Given this list of marker genes GSTT2, DPAGT1, BNIP2, DENND4C, COLQ, DDX3Y, TWF2, ARHGAP17, CSNK1A1, ANXA3, ALYREF, MPG, FEN1, MED31, here is a description of the gene set: 3-Aminobenzamide (3AB) is an inhibitor of poly (ADP-ribose) polymerase (PARP), an enzyme implicated in the maintenance of genomic integrity, which is activated in response to radiation-induced DNA strand breaks. cDNA macroarray membranes containing 1536 clones were used to characterize the gene expression profiles displayed by mouse BALB/3T3 fibroblasts (A31 cell line) in response to ionizing irradiation alone or in combination with 3AB. A31 cells in exponential growth were pre-treated with 3AB 4mM 1h before gamma-irradiation (4Gy), remaining in culture during 6h until harvesting time. A31 cells treated with 3AB alone presented a down-regulation in genes involved in protein processing and cell cycle control, while an up-regulation of genes involved in apoptosis and related to DNA/RNA synthesis and repair was verified. A31 cells irradiated with 4Gy displayed genes differentially expressed, being detected a down-regulation of genes involved in protein processing and apoptosis, and genes controlling the cell cycle. Concomitantly, another set of genes for protein processing and related to DNA/RNA synthesis and repair were found to be up-regulated. A positive or negative interaction effect between 3AB and radiation was verified for 29 known genes. While the combined treatment induced a synergistic effect on the expression of LCK proto-oncogene and several genes related to protein synthesis/processing, a negative interaction effect was found for the expression of genes related to cytoskeleton and extracellular matrix assembly (SATB1 and Anexin III), cell cycle control (tyrosine kinase), and genes participating in DNA/RNA synthesis and repair (RNA helicase, FLAP endonuclease-1, DNA-3 glycosylase methyladenine, splicing factor SC35 and Soh1). The present data open the possibility to investigate the direct participation of specific genes, or gene products acting in concert in the mechanism underlying the cell response to radiation-induced DNA damage under the influence of PARP inhibitor. Human Gene Set: CARDOSO_RESPONSE_TO_GAMMA_RADIATION_AND_3AB Down-regulated synergystically by gamma-irradiation and 3-aminobenzamine, an inhibitor of PARP1. species: Mus musculus from publication Cardoso RS, Espanhol AR, Passos GA, Sakamoto-Hojo ET (PMID 12379459)